Given this list of marker genes Tex101, Pi4k2a, Prg3, Enpp3, Kars1, here is a description of the gene set: studied in species Mus musculus The change in morphology and behavior of a basophil resulting from exposure to a cytokine, chemokine, soluble factor, or to (at least in mammals) an antigen which the basophil has specifically bound via IgE bound to Fc-epsilonRI receptors. Mouse Gene Set: GOBP_BASOPHIL_ACTIVATION